Given this list of marker genes SLC6A13, SLC36A1, SLC6A6, SLC6A11, SLC16A6, here is a description of the gene set: Human Gene Set: GOMF_TAURINE_TRANSMEMBRANE_TRANSPORTER_ACTIVITY Enables the transfer of taurine from one side of a membrane to the other. Taurine (2-aminoethanesulfonic acid) is a sulphur-containing amino acid derivative which is important in the metabolism of fats. studied in species Homo sapiens